Given this list of marker genes NOTCH1, DRD2, CX3CR1, ASPM, FZD3, CTNNB1, SHH, VEGFA, GLI3, HIF1A, NR2E1, DMRTA2, SMARCD3, FOXG1, WDR62, ITGB1, DCT, PAX6, VEGFC, CX3CL1, ID4, CDON (NCBI Gene Id 50937), DISC1, ZNF335, OTP, SMO, SOX10, FGF2, KDM1A, here is a description of the gene set: studied in species Homo sapiens Human Gene Set: GOBP_POSITIVE_REGULATION_OF_NEUROBLAST_PROLIFERATION Any process that activates or increases the rate of neuroblast proliferation.